Given this list of marker genes CKMT1B, COPRS, MPPED2, CDKN1A, PLD5, NOL4, CSRP3, TIMM23, HOXA3, LEFTY2, ADAMTS15 (ADAM metallopeptidase with thrombospondin type 1 motif 15), DUSP3, IL23R, KLHL34, STAC2, CHD2 (NCBI Gene Id 283680), GFPT2, NKX6-3, C3orf18, TFAP2C, CHMP3, MID1, CNNM1, MTX2, COX6C, CDHR5, PLA2G5, EPHA7, ELK3, SLC4A7, MAPRE1, ELAVL1, CPLX2, NR2F6, DOCK4, PITX1, NR6A1, GREM1, GLUD1, CREB3 (NCBI Gene Id 10488), CRABP2, DCHS1, NEFH, TMEM270, ZMAT4, BZW2, SLC16A6, BCL2L13, CCDC88A, RFX1, SLC16A13, PARP6, HIPK2, MASP1, STEAP2, CCDC9B, STOML2, CEP97, PRG2, CCDC136, CAPN12, CAMTA2, PCDH18, CDK13, PNLIPRP2, KCNIP4, EFNA3, STAU1, MNT, SLC7A3, CNTLN, RAP2C, SNTG1, GABRG2 (gamma-aminobutyric acid type A receptor subunit gamma2), TPPP3, SSR4, FOXF2, DTNB, HPX, CDKL5, EPG5, BTBD3, HCK, KIF5A, TBX6, HIBADH, ELF4, XPO6, CYP39A1, SPAG9, TOMM40, FGFR3, ZNF532, ATP6V1B1, SIRPA, TINAG, MAP2K7, GPR3, ASTN1 (astrotactin 1), B4GALT2, TNFRSF12A, MANF, EYA3, MYADM, CLUH, RIMS4, GCM1, HMGB3, NDUFA5, FGF12, EEF1A2 (eukaryotic translation elongation factor 1 alpha 2), SLC25A3, HTATSF1, NR2C2, ZDHHC5, MMEL1, TCF7L2, KCNK4, HOXC13, RHOQ, C7orf33, UBE2R2 (ubiquitin conjugating enzyme E2 R2), FMNL1, SMPD1, GRID2, CDK14, ZBTB33, SLC8A3, STMN1, UQCRC1, NUFIP2, COX5A, ESRRA, SOX12, UBE2K, KIRREL3, NXPH4, ZFP36L1, RGS7, ELAPOR1, FBXL22, HOXA5, CYP26A1, MINK1 (NCBI Gene Id 50488), TMEM106C, UHRF2, DAB2, SLC22A6, EPN3, SOX2, RELL2, BCL6, PPP4R3A, ITGB8, FAM20C (NCBI Gene Id 56975, FAM20C golgi associated secretory pathway kinase), PLEKHG6, CD37, ARFGEF1, ONECUT2, GATA4, CYC1, MYBPC2, DACT2, PSD3, ADAMTS8, FHL1, SYT17, POU5F1, TEX12, ADAMTS14, TBX5, CHCHD4, KMT2E, SATB1, FH, HPCAL4, PHF1, BTG2, TMEM38A, FSBP, ADAMTSL3 (ADAMTS like 3), SCT (NCBI Gene Id 6343), SRSF3, MADD, LINC00487, HOXA10, EFNB2, FGFR2, DBNDD2, SPATA7 (NCBI Gene Id 55812), GRM1, IL17RE, EFHD1, IDH3A, ATP5PO, MCRS1, FZD4, TLN1 (NCBI Gene Id 7094), INPP5F, MEF2D, REV3L, CTU1, TET1, GFAP, NRSN2, LAMB2, TIAL1, UTP18, RCOR2, ST3GAL1, CUTA, SH3BP1, MAFB, CEBPB (CCAAT enhancer binding protein beta), MROH5, CLDN12, TEX35, SLC25A27, YBX2, SMARCA1, AOC2, FBXW7, TCF7, GRIA4, VEGFA, GAL3ST3, ALPI, SCHIP1, JPH2, CYP21A2, MROH7, OVOL2, CNTF, COMMD3, ASB8, LEFTY1, PPM1E, ALPG, BDNF, COX7B, LCP1, NDRG2, GABARAPL2, LRPPRC, DCX, IRF2BPL, IDH3G (NCBI Gene Id 3421), SPOCK2, BRAF, WNT2, TMEM43, SLCO3A1, MAP1LC3A, OSGIN1, PAX6, DCTN2, PLXNB1, PIP4K2A, MAST1, here is a description of the gene set: Human Gene Set: ER_Q6_02 Genes having at least one occurrence of the motif NAGGTCANNNY in the regions spanning 4 kb centered on their transcription starting sites. This matches the ESR1 transcription factor binding site V$ER_Q6_02 (v7.4 TRANSFAC). species: Homo sapiens